The following is a description of a gene set: Genes up-regulated in epithelial cells (24h): IFNG versus interferon alpha. Human Gene Set: GSE5542_IFNG_VS_IFNA_TREATED_EPITHELIAL_CELLS_24H_UP from publication Sanda C, Weitzel P, Tsukahara T, Schaley J, Edenberg HJ, Stephens MA, McClintick JN, Blatt LM, Li L, Brodsky L, Taylor MW (PMID 16800785) species: Homo sapiens Type I and type II interferons (IFNs) bind to different cell surface receptors but activate overlapping signal transduction pathways. We examined the effects of a type I IFN (IFN-acon1) and a type II iFN (IFN-g1b) on gene experession in A549 cells and demonstrate that there is a common set of genes modulated by both IFNs as well as a set of gene specifically regulated by each, reflecting the activation of different signaling pathways. In particualr, IFN-g induced many more genes of the signaling pathways, apoptosis, and cytokine interactions than did IFN-a. Even with genes induced by both IFNs there were distinctive quantitativive differences in expression. IFN-g1b plays a major role in the induction and regulation of the complement pathway. Previous work has shown a synergistic antivral and antiproliferative effect of type I and type II IFNs in cell culture and in the treament of tumors in mice. We demonstrate that a majority of genes showed and additive effect of IFN-acon1 and IFN-g1b, but a subset of gene is synergistically induced; these incluce ISG10, MX2, OAS2, and other genes known to be involved in the antiviral response, TRAIL (TNFSF10) and caspases involved in apoptosis and chemokine genes RANTES, CXCL10, and CXCL11. Greater than additive transcription of some of these genes in the presence of both IFNs was confirmed by real-time kinetic RT-PCR. Elevated induction of many of these genes may be sufficient to explain the synergistic antiviral and antitumor effects of this combination of IFNS in vivo., and this is the list of marker genes: SMPD4, AUNIP, COX8A, DSCAML1, BUB3, CEP72, NOXO1, LRRC8D, RAD51B, NT5C2, SEPTIN1, KIFAP3, MRE11, AACS, EXOSC3, GTSE1, UBA5, PLPP6, APPBP2, CDR2, PLXNB2, PFKFB1, CIT, SKA3, CNOT6, GADD45A, ZMYM1, MRPL20-AS1, LRR1, NANS, ADAM17, ELAVL1, LAP3, USP11, ERH, SH3BGRL, PTPN4, PRDX2, SLC35A3, PKP4, RHOG (ras homolog family member G), CCDC122, CDC27, FABP5, SLC25A13, FAM81A, CFAP20, PTK2, NEURL1B, RWDD2B, SCLT1, ZNF207, OSBPL3, DDB1, USP2, TRAIP, GMDS, CIBAR1, DDIAS, RNPEP, MIS12, ILF3, IMP4, GYG1, DLG3, CCDC34, IDH2, NUCKS1, NT5C3B, DMAC2L, MAP4K5, UBA2, ATXN10, FAM221A, ZFP91, MYBL2, NELFE, ELOVL6, TMEM165, SMC5, TINF2, MFSD6, UFL1, GLYR1, SSX2IP, THAP1, SH3BGRL2, LDHA, ARHGAP25, CORO1C, GSTT2, KCMF1, LNX2, EPS8L1, NDE1, POLE3 (DNA polymerase epsilon 3, accessory subunit), PADI2, STRAP, HMGN5, RAF1, RAD51C, TEX9, RBM44, REEP4, LSM14A, EIF3C, STARD9, NCBP1, DNM1L, EIF3J, LXN, NUDT4, PHF6, LINC01160, MYL4, ZNF280D, TBC1D31, ARPC1A, STX18, POP4, PPM1G, MCPH1, UCHL5, LPXN, CSTF3, UBAC2, THOC6, TRIP12, NDUFAF3, NIPA2 (NCBI Gene Id 96367), SCARB2, HNRNPA3, RCC1, PMS2, ING2 (NCBI Gene Id 3622), FAM135A, CCHCR1, PAQR3, CTH, PEX19, NKAP, KCNK6, S1PR3, ACTR1B, NUP205, RYK, MYEF2 (myelin expression factor 2), EHD3, GCFC2, FAM216A, ARPC5L, CCNF, UBE2K, BBS10, SFMBT1, USP1, PSMB2, SLC16A1, CMAS, RFC3, MTCP1, GPATCH2, WDR35, WDR90, ERI2, PSMD4, COQ7, MRPL51, ARHGEF39, CDC7 (NCBI Gene Id 8317), RNF4, SELENOH, SMARCA5, RARRES1, ASB8, SUCO, SMDT1, CXXC1, PRR5, MTRES1, AGFG1, NAMPT, AGPAT3, EAF1, CEP152, LGR5, STAC2 (NCBI Gene Id 342667), FYTTD1, HAUS3, COPRS, CYC1, GTF2H5, HIPK3, SELENOP, OXCT1, DNAJC9, MCM3, QRICH1, VDAC1, CCDC88A